The following is a description of a gene set: studied in species Homo sapiens Human Gene Set: SABATES_COLORECTAL_ADENOMA_SIZE_DN from publication Sabates-Bellver J, Van der Flier LG, de Palo M, Cattaneo E, Maake C, Rehrauer H, Laczko E, Kurowski MA, Bujnicki JM, Menigatti M, Luz J, Ranalli TV, Gomes V, Pastorelli A, Faggiani R, Anti M, Jiricny J, Clevers H, Marra G (PMID 18171984) A selection of genes whose expression displayed significant negative correlation with size of colorectal adenoma. Colorectal cancers are believed to arise predominantly from adenomas. Although these precancerous lesions have been subjected to extensive clinical, pathologic, and molecular analyses, little is currently known about the global gene expression changes accompanying their formation. To characterize the molecular processes underlying the transformation of normal colonic epithelium, we compared the transcriptomes of 32 prospectively collected adenomas with those of normal mucosa from the same individuals. Important differences emerged not only between the expression profiles of normal and adenomatous tissues but also between those of small and large adenomas. A key feature of the transformation process was the remodeling of the Wnt pathway reflected in patent overexpression and underexpression of 78 known components of this signaling cascade. The expression of 19 Wnt targets was closely correlated with clear up-regulation of KIAA1199, whose function is currently unknown. In normal mucosa, KIAA1199 expression was confined to cells in the lower portion of intestinal crypts, where Wnt signaling is physiologically active, but it was markedly increased in all adenomas, where it was expressed in most of the epithelial cells, and in colon cancer cell lines, it was markedly reduced by inactivation of the beta-catenin/T-cell factor(s) transcription complex, the pivotal mediator of Wnt signaling. Our transcriptomic profiles of normal colonic mucosa and colorectal adenomas shed new light on the early stages of colorectal tumorigenesis and identified KIAA1199 as a novel target of the Wnt signaling pathway and a putative marker of colorectal adenomatous transformation., and this is the list of marker genes: TBX10, TMEM125, SYT17, GNPTAB, RCAN3, CYSLTR1, BNIP1, RETNLB, C2orf72, GLDN (NCBI Gene Id 342035), PDE4D, MMP28, MAOA (NCBI Gene Id 441491)